Given this list of marker genes Csf2, Tlr4, Il17ra, Myd88, Tgfb1, Ifng, Plcg2, Rac1, Il1rl2, Il17a, Clec7a, here is a description of the gene set: Mouse Gene Set: GOBP_INTERLEUKIN_23_PRODUCTION The appearance of interleukin-23 due to biosynthesis or secretion following a cellular stimulus, resulting in an increase in its intracellular or extracellular levels. species: Mus musculus